Given this list of marker genes PIK3CB, RAC1 (Rac family small GTPase 1), PIK3CG, AKT1, KLF14, SCARB1, GPR3, S1PR3, S1PR4, PLPP3, S1PR5, SPNS2, S1PR1, MFSD2B, EZR, SPHK1, S1PR2, SMPD3, GPR6, SPHK2, here is a description of the gene set: The series of molecular signals mediated by a sphingolipid. species: Homo sapiens Human Gene Set: GOBP_SPHINGOLIPID_MEDIATED_SIGNALING_PATHWAY